Given this list of marker genes PPP1R16A, DMPK, PPP1R12B, PPP1R12A, PPP1R12C, PPP1R16B, here is a description of the gene set: species: Homo sapiens Binds to and modulates of the activity of myosin phosphatase. Human Gene Set: GOMF_MYOSIN_PHOSPHATASE_REGULATOR_ACTIVITY